Given this list of marker genes NOS2, REEP1, PPP1R2 (protein phosphatase 1 regulatory inhibitor subunit 2), ADD3, FABP4, RMND5A, ACSL3, BUB1 (NCBI Gene Id 699), KIF2C, EMP2, SMC4, PPARG, GPRC5B, BTBD3, PLK1, PEG10, NDRG1, CLEC4M, SLC39A14, CDK1, GRAP, ITGA9, KALRN (NCBI Gene Id 8997), HOXD10, NDC80, CKS1B, LIPA, LMNB1, FOXM1, CSRP2, CEP68, DMTN, MAOA, CCNB2, UNC5B, PAQR3, IGFBP2, GAB1, PDPN, CRMP1, HACD2, RAMP3, LYN, PCLAF, PDLIM1, OLFML2A (olfactomedin like 2A), TK1, ANKS1A, TUBA4A, KIF11 (kinesin family member 11), TIMP3, RBP1, NR2F1, PRKCZ, TBX1, TBXA2R, MEF2C, AURKB, NPTX2, DCLK1, USP13, CREM, PTTG1, RAMP2, RBPMS, PROX1, SOCS2, FLT4, CEACAM1, IQGAP2, SLC26A4, RAPGEF5, UBE2C, LBR (NCBI Gene Id 653311), SMAGP, CH25H, CENPF, TTK, PCSK6, CTDSPL, MAF (MAF bZIP transcription factor), RAB31, LAMP3, SPRY1, HMGB2, DHCR24, CALCRL, GINS1, PLPP1, SELENOP, PDLIM3, ANGPT2, MYBL2, ALDH1A1, PYGL, GMFG, ARRB2, MGP, TOP2A, ARID5B, BUB1B, DUSP5, CDKN3, HLA-DPB1, MCM6, JCAD, CCNE2, APOD, CYP1A1, LMO2, CD200, CETP, TFF3, RGS16, SPAG5, IL7, H4C3, PNP, CCNA2, GCH1, CXCL12, PDE8A, LDB2, MRC1, CCNB1, ISG20, RELN, DYRK3, ITGA1, DSP, CDKN1C, here is a description of the gene set: studied in species Homo sapiens Genes up-regulated in LEC (lymphatic endothelial cells) compared to BEC (blood endothelial cells). from publication Petrova TV, Mäkinen T, Mäkelä TP, Saarela J, Virtanen I, Ferrell RE, Finegold DN, Kerjaschki D, Ylä-Herttuala S, Alitalo K (PMID 12198161) Lymphatic vessels are essential for fluid homeostasis, immune surveillance and fat adsorption, and also serve as a major route for tumor metastasis in many types of cancer. We found that isolated human primary lymphatic and blood vascular endothelial cells (LECs and BECs, respectively) show interesting differences in gene expression relevant for their distinct functions in vivo. Although these phenotypes are stable in vitro and in vivo, overexpression of the homeobox transcription factor Prox-1 in the BECs was capable of inducing LEC-specific gene transcription in the BECs, and, surprisingly, Prox-1 suppressed the expression of approximately 40% of the BEC-specific genes. Prox-1 did not have global effects on the expression of LEC-specific genes in other cell types, except that it up-regulated cyclin E1 and E2 mRNAs and activated the cyclin e promoter in various cell types. These data suggest that Prox-1 acts as a cell proliferation inducer and a fate determination factor for the LECs. Furthermore, the data provide insights into the phenotypic diversity of endothelial cells and into the possibility of transcriptional reprogramming of differentiated endothelial cells. Human Gene Set: PETROVA_ENDOTHELIUM_LYMPHATIC_VS_BLOOD_UP